Given this list of marker genes ZNF398, COASY, CDKN2AIPNL, MIR320A, MED20, IFT80, SCARNA2, SLC38A1, GRK4, SEPTIN7, BANP, ACTB, RRP1B, RRP8, ENSG00000293341, GOT2, NCBP3, CLASP1, RCOR1, TFB2M, VRTN, ACTG1, CDC25B, NIP7, AKAP11, SEPTIN1, FAM86B3P, BRIX1, HDAC6, ENSG00000280424, KLHL21, RBM39, EMD, COX4I1, PCNP, SNORD46, GNAI1, TEX261, TMEM199, RPL12 (NCBI Gene Id 90679), THOC1-DT, IREB2, FEM1C, YTHDF2, TRIM52-AS1, MKKS, CDK12, VAV1, SNHG16, HNRNPH3, MTIF2, SNHG11, MRGBP, M6PR, STUB1, SNORA50C, EPC1, ANKRD46, CEP95, SNORD55, RPS8 (NCBI Gene Id 6202), IDH3B, SSNA1, WDR5B, NDUFB7, RPL18, CYB5D1, BNIP3L, COX7A2, RPS3A, DNAJB11, SPHK2, ERLIN2 (ER lipid raft associated 2), HIF1AN, TOR1AIP1, RPL7A, ARHGEF1, SEM1, ZNF629, SATB2, SNHG17, PPP4R3B, SSRP1, ADNP, MSL2, CTDSP2, PFDN5, FCHSD2, PRPF8, FNTA (NCBI Gene Id 2339), HDLBP, ZFP62, CSPP1, WDR1, ZNF23, ZNF497-AS1, ZFTRAF1, ZNF319, RBM25 (NCBI Gene Id 58517), RINT1, CACYBP, RAI1, PPP4R3B-DT (NCBI Gene Id 107985885), LZIC, COPS8-DT, ATN1, SEPTIN2, PPIA, TIMM10, GTPBP3, CCDC90B-AS1, HSPA4, PPP4R1, RPS11, ATXN2L, ZNF48, SNORA16A, CERNA3, THOC1, ARL14EP, SLC30A6-DT, FRS3, PPP1R12A, ARK2N, SNHG25, EFCAB7, ERGIC2, CIPC, CAMSAP2, MEF2A, COPS8, MYO15B, ZKSCAN5, ADPRS, ITGB3BP, COG8, SP3, ZNF202, MRPL57, USP22, NFATC3, SNHG8, TRIM46, TCF3, AP5Z1, IST1, ZCCHC4, UBXN6, PUF60, RPS20, TMTC4, GIPC2, RPS7, ZNF79, ZNF787, DHX30, RPL37A, SUMO1, SLC30A6 (NCBI Gene Id 55676), DIDO1, YLPM1, MIR6853, SMG7, ERCC6L2-AS1, TUFM, ZNF410, TBC1D12 (TBC1 domain family member 12), JRK, HNRNPUL1, TRIAP1, KDM1A, NIFK-AS1, JADE2, DNAJC16, EEF2, SNHG12, RPL10A, HOTTIP, MTCO3P12, WDR43, POLDIP2, DNAJB4, WDR5B-DT (NCBI Gene Id 102723582), MAP3K7, HOXB5, MYLIP, TMEM209 (transmembrane protein 209), NEK4, SNORD54, NOM1, RAD1, RBPJ, CIAO3, EIF5A, CUEDC2, GGA1, ERCC6L2, RNA5SP155, CCDC90B, IRF2BP1, ZZZ3, IDH3B-DT (IDH3B divergent transcript), MIR3619, H3-3B, GOLGA7, MACO1, LINC00938, PHIP, CENPB (NCBI Gene Id 92501), PRPSAP1, POLR3C, GFUS, TBCCD1, ATP9B, EIF3G, YOD1, WDR70, EEF1AKMT2, BYSL, HUWE1, TRAF6, UCHL5, SATB1, SDAD1P1, MCRIP1, NAA38 (N-alpha-acetyltransferase 38, NatC auxiliary subunit), LINC02980, TNIP2, DNAJC7, TIPIN, RNF167, DPY19L4, INTS4, SMC4 (structural maintenance of chromosomes 4), R3HCC1, NMNAT1, ZNF250, CENPT, RNA5SP473, CNOT8, TUBGCP5, PRKAB2, MED22, P2RX4, SNRPE, GTF3C5, PCM1, MYCBP2, ANAPC2, KIFC2, HGSNAT, ZNF35, CORO7 (coronin 7), SNORA24, ABCD4, PCBP2, MIR4638, MFSD3 (major facilitator superfamily domain containing 3), S100A6, HOXA9, FUBP1, KRTCAP2, NUP155, LRSAM1, UBE2J2, ILK, SH2B1, ZNF445, HENMT1, ZNF251, KLRG1, MELTF-AS1, RPS19, ERCC1, AURKAIP1, AGAP3, COA1, COPS5, DNAJA3, ADGRE5, PPP4R1-AS1 (NCBI Gene Id 101927323), DDX5, TAS1R1, TRIM41, ZSCAN25, TBPL1, RPL27A, KMT5A, RPL37A-DT, NLE1, KCTD5, ZSCAN12, MOSPD3, AXIN1, ATXN1L, CNST, COPA, LINC02642, CYP1A1, SF3A3, RRN3, SKA3, USB1, TMEM18, SEPTIN7-DT, POLR1H, MAPK14, GLI4, PSCA, TOMM22-DT, ARHGAP45, HSF2BP, EMC8, SLC35D1, NARS1, TNPO2, DENR, NOL9, MDC1, FIS1, CREB3, YBX1, RPL10, LINC01347, TRIM52 (NCBI Gene Id 90940), POLR1HASP, CNP, UPF3A, EPC1-AS1, POLQ, MRPS33, TGOLN2, TOMM22, VSIG10, ORC5, TLN1 (talin 1), SLC25A11, IFRD1, POLR3D, ZNF367, NCSTN, RO60, SRRM3, HOXB6, MARCHF10, SNORD104, EIF5, KDM3B, CASP9, DUSP12, CLEC11A, SCYL3, MPV17L, PSMD6, NUP214, CHPF2, SNORA44, SMG7-AS1, NOP14, RAG1, GATC, PPIL4, RNF115, here is a description of the gene set: Genes containing one or more binding sites for (NPM1) in their promoter regions (TSS -1000,+100 bp) as identified by GTRD version 20.06 ChIP-seq harmonization. from publication Yevshin I, Sharipov R, Kolmykov S, Kondrakhin Y, Kolpakov F (PMID 30445619) studied in species Homo sapiens Human Gene Set: NPM1_TARGET_GENES